The following is a description of a gene set: studied in species Homo sapiens part of: Gamma carboxylation, hypusinylation, hydroxylation, and arylsulfatase activation A number of proteins, including eight required for normal blood clot formation and its regulation (Prothrombin (factor II), factor VII, factor IX, factor X, protein C, protein S, protein Z, and Gas6) share a sequence motif rich in glutamate residues near their amino termini. Carboxylation of the glutamate residues within this motif followed by removal of an aminoterminal propeptide is required for each of these proteins to function. These modifications occur as the proteins move through the endoplasmic reticulum and Golgi apparatus. Reactome Pathway: Gamma-carboxylation, transport, and amino-terminal cleavage of proteins, and this is the list of marker genes: BGLAP, GAS6, PROC, PROS1, F7, F9, PROZ, GGCX, F2, FURIN, F10